Given this list of marker genes Urm1, Elp1, Dph3, Trmu (tRNA 5-methylaminomethyl-2-thiouridylate methyltransferase), Mto1, Trmt9b (tRNA methyltransferase 9B), Elp2, Alkbh8, Gtpbp3, Ctu1, Elp3 (elongator acetyltransferase complex subunit 3), Elp5, Elp4, Mocs3, Ctu2, Elp6, Kti12, here is a description of the gene set: studied in species Mus musculus The process in which a uridine in position 34 of a tRNA is post-transcriptionally modified. Mouse Gene Set: GOBP_TRNA_WOBBLE_URIDINE_MODIFICATION